Given this list of marker genes SDC1, LGALS13, ENSG00000256389, LYPD5, RRS1-DT, RHOBTB3 (Rho related BTB domain containing 3), CPXM2, PSG6, LY6G6C, TMEM54, ALPP, C4orf36, HSD17B1, HOPX, LINC00967, PSG5, TREML2, NCF4-AS1, TRPV6, INHBA, KISS1 (NCBI Gene Id 3814), SEMA3B, MISP3, CSH2, PSG10P, ENSG00000243273, PRSS41, PSG4, DEPDC1B, ANGPT2, ENDOU, SLC7A4, HSPB8, CCK, TCHH, PSG3, XKRX, LINC00474, CSHL1, LINC00482, HSD11B2, SLC26A7, TFPI2, ANKRD33, CAPN6, PLCE1-AS1, LINC00939, INSL4, CHODL, HSPD1P11, PSG11, CSH1, MAN1C1, POU2F3, TREML3P, TCL6, NECTIN3, PSG8, SCNN1B, CRH, HS3ST3B1, GH2, HSD3B1, PSG8-AS1, CRYBG2, PSG9 (NCBI Gene Id 91052), ADHFE1, LINC01483, CCSAP (centriole, cilia and spindle associated protein), PSG2, SH2D5, ZNF468, PSG1, LGALS16, PSG7, ERV3-1, CGA, AFF1, CGB3, CYP19A1, GDF15, IL22RA2, LINC01118, BPGM, OLAH, TPRXL, PSCA, LINC02291, LGALS14, RYBP, ZNF117 (zinc finger protein 117), GH1, here is a description of the gene set: Human Gene Set: DESCARTES_FETAL_PLACENTA_TROPHOBLAST_GIANT_CELLS studied in species Homo sapiens from publication Cao J, O'Day DR, Pliner HA, Kingsley PD, Deng M, Daza RM, Zager MA, Aldinger KA, Blecher-Gonen R, Zhang F, Spielmann M, Palis J, Doherty D, Steemers FJ, Glass IA, Trapnell C, Shendure J (PMID 33184181) Marker genes curated from the annotated cluster as represented in the Descartes Human Gene Expression During Development database. The gene expression program underlying the specification of human cell types is of fundamental interest. The study authors generated human cell atlases of gene expression and chromatin accessibility in fetal tissues. For gene expression, the study authors applied three-level combinatorial indexing to >110 samples representing 15 organs, ultimately profiling ~4 million single cells. The study authors leveraged the literature and other atlases to identify and annotate hundreds of cell types and subtypes, both within and across tissues. Our analyses focused on organ-specific specializations of broadly distributed cell types (such as blood, endothelial, and epithelial), sites of fetal erythropoiesis (which notably included the adrenal gland), and integration with mouse developmental atlases (such as conserved specification of blood cells). These data represent a rich resource for the exploration of in vivo human gene expression in diverse tissues and cell types.